The following is a description of a gene set: Any process that results in a change in state or activity of a cell (in terms of movement, secretion, enzyme production, gene expression, etc.) as a result of an abiotic (non-living) stimulus. Mouse Gene Set: GOBP_CELLULAR_RESPONSE_TO_ABIOTIC_STIMULUS species: Mus musculus, and this is the list of marker genes: Bdkrb2, Fbxo4, Gh, Rad23a, Rad9b, Bax, Ddx3x, Kcnk4 (NCBI Gene Id 16528), Mir3473c, Grk1, Serpinb6e, Mir495, Mtpn, Map3k14, Ptafr, Mir194-2, Hus1, Mlst8, Cnn2, Myd88, Map3k20, Ifi207, Mapk14, Mir301, Rad23b, Slc12a6, Mir379, Tlr7 (toll-like receptor 7), Hyal1 (hyaluronoglucosaminidase 1), F11r, Mir29c, Dag1, Clcn2, Gsk3b (glycogen synthase kinase 3 beta), Fgf2, Bad, Pold1, Relb, Fignl1, Mir5621, Hpca, Mmp9, Ptger4, Dysf, Ang (angiogenin, ribonuclease, RNase A family, 5), Mir760, Mir137, Opn1sw, Pbk, Crip1, Akt1, Mndal, Mir1895, Map2k4, Pkd2l1, Kcnk18, Sox9, Parp1, Prkcd, Actr5, Kcnk9, Trpm1, Scn2a, Rnf4, Snai2, Tmem87a, Mylk, Rhno1, Piezo1, Mmp3, Eef1d, Mir410, Mir434, Habp4, Trpv4, Mapk13, Opn3, Gata3, Abcb1a, Rest, Bnip3, Ruvbl2, Brca2, Bcl10, Mir30b, Capn3, Pola1, Ascl1, Trp53inp1 (transformation related protein 53 inducible nuclear protein 1), Nlrp3, Epo, Mir652, Serpinb6c, Rrh, Bcl2l1, Rad51, Timp1, Rac1, Trpv3, Casp3, Ptpn11, Pax2, Babam2, Tgfb1 (transforming growth factor, beta 1), Ybx3, Mapk3, Rhob, Mir5128, Kcnk1, Blm, Ino80, Il1b (interleukin 1 beta), Wrn, Cdkn2a, Mir29b-2, Tlk2, Sfrp1, Ifi206, Tspo, Plec, Mag (myelin-associated glycoprotein), Gpr88, Ifi203, Ednra, Actb, Hyal3, Mir148b, Xrcc6, Sde2, Map2k7, Gna11, Tnks1bp1, Gtf2h5, Ripor2, Mtch2, Ints7, Casp9, Rbx1, Cryab, Nlrp1a, Fbp1, Slc25a23, Opn1mw, Akr1b1, Cln3, H2aj, Tmem109, Eif2ak4 (NCBI Gene Id 27103), Mir26a-1, Lig4, Rgr, Gja1, Slc24a4, Cradd, Ltbr, Scn7a, Tmem150c, Slc38a2, Chek2, Mcoln1, Opn5, Tspyl5, Rpl26, Grm1, Egr1, Mir511, Mir300, Micu1, Bard1, Ep300, Mir26a-2, Rgs9, Chek1, Tnfsf14, Mapk11, Slc2a1, Bak1, Ect2, Mmp1a, Polh, Ercc4, Col1a1, Stk11, Brcc3, Rab11b, Clock, Cers1, Nucks1, Zbtb1, Slc2a4, Mapk9, Mme, Mir695, Ptgs2, Eng, Irf1, Scnn1a, Kcnj2, Pierce1, Nos3, Triap1, Casp2, Ifi213, Bag3 (BCL2-associated athanogene 3), Rad9a, Aqp1, Ddb1, Pcna, Tnfrsf1a, Got1 (NCBI Gene Id 14718), Pde2a, Mir101b, Poli, Atp1a2, Sipa1, Neurod2, Mir154, D1Pas1, Bmp6, Pycard, Mkx, Ciita, H2ac25, Tnf, Grb2, Stk39, Eif2s1, Noc2l, Hvcn1, Mir125b-1, Mettl3, Nos1, Ninj1, Mir376a, Cul4a, Itgb6, Myo6, Smpd1, Net1, Vps13a, Mmp2, Mir1192, Mir9-3, Mir7b, Cd40, Rpgr, Akt2, Ifi214, Gclc, Wnk1 (WNK lysine deficient protein kinase 1), Mfap4, Pold3, Scx, Aqp5, Npm1, Pcp2, Letm1, Elk1, Rhbdd1, Xrcc5, Mc1r, Rptor, Mir99a, Yap1, Scnn1b, Tlr4, Gnat1, Trp53, Cops9, Agap3, Prkg2, Atr, Nfatc4, Zmpste24, Ddb2, Efhd1, H2ax, Fbxw7, Spidr, Ppid, Gpr68, Trex1, Wnt11, Serpinb6a, Pkd1l3, Nscme3l, Pkd2, Mir451a, Hyal2, Gnb5, Scnn1g, Rbx1-ps, Brcc3dc, Serpinb6d, Mir9-2, Chp1, Il33, Opn4 (NCBI Gene Id 30044), Kcnk3, Hras, Cul4b, Mtor, Mmp1b, Zfp36l1, Asic2, Usp28, Tifab, Ccnd2, Tmem161a, Ankrd1, Bbc3, Ifi209, Hsf1, N4bp1, Nsmf, Xpa, Aurkb, Mir691, Crb1, Piezo2, Rad1, Tank, Trpv1, Adss2, Tlr3, Pik3ca, Nedd4, Fadd, Slc9a1, Rad51ap1, Wnk3, Bmf, Rho, Mir100, Atm, Mir214, Itgb3, Ercc1, Gpld1, Cdkn1a, Palm, Mir204, Egfr, Ddias, Nfkb1, Arhgdia, Mir665, Calr, Slc4a11, Kdm1a (lysine (K)-specific demethylase 1A), Usp15, Kcne1, Itga2, Aipl1 (aryl hydrocarbon receptor-interacting protein-like 1), Nsmce3, Pten, Gadd45a, Rp1, Tlr8, Mir29b-1, Mir92-2, Lrrc8e, Asic1, Mir3092, Casp1 (caspase 1), Nipbl, Ei24 (NCBI Gene Id 13663), Cav1, Prap1, Mir143, Rcsd1, Swi5, Sirt1, Rab11fip5 (RAB11 family interacting protein 5 (class I)), Lrrc8c (leucine rich repeat containing 8 family, member C), Crebbp, Ptprk, Kdm4d, Atp1a1, Ifi203-ps, Mdm2, Nlrp1b, Yy1, Gpr52, Ctnnb1, Insrr, Oxsr1, Mir208a, Rnf168, Nlk, Lrrc8d, Brca1, Cdc25a, Avpr1a, Mir9-1, Aqp2, Ifi208, Dhx36, Sfrp2, Polk, Pck1 (NCBI Gene Id 98888), Serpinb6b, Trp53bp1, Xpc, Pik3r1